The following is a description of a gene set: Mouse Gene Set: GOCC_CHAPERONIN_CONTAINING_T_COMPLEX studied in species Mus musculus A multisubunit ring-shaped complex that mediates protein folding in the cytosol without a cofactor., and this is the list of marker genes: Tcp1, Cct6a, Cct7, Cct4, Cct6b, Cct8l1, Cct2, Cct3 (chaperonin containing TCP1 subunit 3), Cct8, Cct5